Given this list of marker genes MSH2, ZW10, CENPC, KIF2C, MLH3, CENPB, here is a description of the gene set: Binding to a centromere, a region of chromosome where the spindle fibers attach during mitosis and meiosis. studied in species Homo sapiens Human Gene Set: GOMF_CENTROMERIC_DNA_BINDING